Given this list of marker genes Itm2b, Mif4gd, Cxcr3, Ubc, Asap1, Xist, Gpx4, Gimap3, Ubb, Dad1, Cd3g (CD3 antigen, gamma polypeptide), Pkp3, Tnfaip8, Bsg, Atp5pf, Ube2i, Glrx, Ptpn11, Ahnak, Lrp10, Srgn, Tiam1, Ier5, Atp2b1, Zfp36l1, Cd82, Tspan3, Psmb8 (NCBI Gene Id 16913), Psme1, H2-D1, Jchain, H3f3b, Txndc17, Cd5, Syt11, Map1lc3b, Ifi27, Neat1, Gng2, Psenen, Cox7c, Sumo1, Ptpn22, Tmbim4, Tpi1, Fth1, Itgal, Arf6, Tnfrsf4, Sdcbp2, 2310001H17Rik, Socs3, Bcl2a1d, Sri, Trim8, Batf, Laptm5, Crlf2, Ssr4, Cd44, Pou2f2, Cd6, Pim1, Cox5b, Serpina3g, Prkca, Etfb, Gna13, Pgam1, Ptprcap, Tmem254, Aldoa, Tomm7, Ftl1, Kcnn4, Tmem256, Calr (NCBI Gene Id 12317), Acot7, Ndfip1, Traf1, Maf, Itga4, Ccl5, Gimap7, Prdx2, Rilpl2, Casp1, Tnfrsf18, Cox6c, Lbh, Dusp1, Vasp, Rsrp1, B3gnt2 (UDP-GlcNAc:betaGal beta-1,3-N-acetylglucosaminyltransferase 2), Atp5mc2, Apoe, Rnasek, Pdia3, Mrpl52, Ptms, Sh3bgrl, Gpi1, Cd84, Oaz1, Gpm6b, S100a8, Coro1b, Lag3, Il2rb, AW112010, Gimap4, Cox8a, Celf2, Gimap5, Sdf4, Vim, Pfdn5, H2-K1, Ctla4, Gabarap, Gltp, Rpl38, Prelid1, Tank, Hsp90aa1, Pkm, Elob (NCBI Gene Id 98096), Itgb1, Rap1a, Pglyrp1, Chmp2a, Cd4, Tnfrsf1b, Lime1, Atp5if1, Psma3, Cldn25, Nfkbia, Ly6a, Actg1 (NCBI Gene Id 230535), Myl12b, Ucp2, Scamp3 (NCBI Gene Id 24045), Eea1, Tmbim6, Calm2, Stat3, Lpxn, Cd74, Gdi2, Sh2d1a, Ptpn1, Rac2, Smpdl3a, Krtcap2 (keratinocyte associated protein 2), Cox7a2, Ndufa1, Ctsb, Gstp3, Vamp8, Apobec3, Sec61g, Junb (jun B proto-oncogene), Tspan13, Ctss, Gimap1, Pebp1, H2-Q4, Serinc3, Psmb9, H2-Ab1, Cdk2ap2, Capg, Cd83, Itm2c, Gas5, Hspa5, S100a10, Lgals1, Samsn1, Efhd2 (NCBI Gene Id 99974), Hmgb1, Izumo1r, Anxa2 (NCBI Gene Id 12306), Rbm3, Hif1a, Pold4, S100a9, Icos, Gnas, Txn1, S100a13, Odc1, Jund, Ypel3, Prr13, H2az1, Lcp2, Id3, Sh3glb1, Tnfsf8, Bcl2a1b, Cst7, Cst3, Cox17 (NCBI Gene Id 12856), Rabgap1l, Fundc2, Tmem134, Cd81, B2m, Tspan32, Maz, Nfatc1, Smco4, Fus, S100a6, Ankrd12, Gng5, Sla, Gm8369, S100a11, Tbc1d4 (TBC1 domain family, member 4), Ikzf2, S100a4, Clic1, Nrp1, Ndufa13, Stx6, Baz1a, Clec2d, Arhgap31, Capns1, Plaat3, Atp5mf, Rps27l, Bloc1s1, Ubl5, Cirbp, Ppp1r11, Cox20, Fis1, Timp2, Fyn, Rnh1, Tox, Anp32b, Slc3a2, Vmp1 (vacuole membrane protein 1), Zap70, Cox6b1, Smap1, Pdcd1, Id2, Ptpn7, Gapdh, Polr2e, Malat1, here is a description of the gene set: studied in species Mus musculus Mouse Gene Set: TABULA_MURIS_SENIS_SPLEEN_T_CELL_AGEING from publication Tabula Muris Consortium (PMID 32669714)